The following is a description of a gene set: species: Homo sapiens Genes up-regulated in growing IMR90 cells (fibroblast) after knockdown of RB1 by RNAi. from publication Chicas A, Wang X, Zhang C, McCurrach M, Zhao Z, Mert O, Dickins RA, Narita M, Zhang M, Lowe SW (PMID 20385362) Human Gene Set: CHICAS_RB1_TARGETS_GROWING The RB protein family (RB, p107, and p130) has overlapping and compensatory functions in cell-cycle control. However, cancer-associated mutations are almost exclusively found in RB, implying that RB has a nonredundant role in tumor suppression. We demonstrate that RB preferentially associates with E2F target genes involved in DNA replication and is uniquely required to repress these genes during senescence but not other growth states. Consequently, RB loss leads to inappropriate DNA synthesis following a senescence trigger and, together with disruption of a p21-mediated cell-cycle checkpoint, enables extensive proliferation and rampant genomic instability. Our results identify a nonredundant RB effector function that may contribute to tumor suppression and reveal how loss of RB and p53 cooperate to bypass senescence., and this is the list of marker genes: TOX, AKR1C1, NMI, ADAMTS2, BAALC, NFYB, FAP (fibroblast activation protein alpha), CXCL12, DCN, ANPEP, MCM3, ANP32E, NUPR1, C1orf21 (chromosome 1 open reading frame 21), AXL, GPC6 (glypican 6), PPIG, GINS2, CNTN3, CCDC80, GASK1B, HMMR, MCM7, CENPH, PRICKLE1, CDCA8, CHAC2, PEAR1, CTDSPL2, CDCA7, HAS2, PCDH7, IMPA2, TBL1XR1, PCOLCE, TTK, LUM, CCNB2, DHCR24, CERS6, NAV2, ZFHX4-AS1, CORIN, PLPP3, HERC4, CCNE2, MEIS2, SMARCC1, LRRC15, PSG5, APOBEC3B, RFC4, RUNX1T1, SCARA3, KCNK2, IGFBP3, USP1, RBP1, CRYBG1, EXOSC8, TNFAIP8, UHRF1, TTC3 (NCBI Gene Id 7267), KCNN2, GINS1, KIF20A, RIF1, TMSB15A, SSRP1, CCBE1, NLRP1, TIFA, ELOVL2, JAM2, IFI16, GMPS, SLFN11, NASP, TIMELESS, SCD, CA12, ADGRG6, TOP2A, ADAMTS6, PCLAF, NUSAP1, CDC7, C2CD5, SHMT2, SLC1A4, OLFML3, CDC25B, RARRES1, LSM2, TMEM106C, CENPF, COL3A1, NR2F2, PHGDH, OXTR, ALDH1L2 (NCBI Gene Id 160428), GTSE1, HAUS1, DPF3, DPYSL3, PSAT1, BNC2, KIF4A, DNAJC9, ZNF22 (zinc finger protein 22), PRIM1, NCAPG2, CASP6, MSH2, SULF1, NRXN3, TPX2, PYGL, SLIT2, NEK2, SGO2, S1PR3, LMNA, MSH6, PTX3, MEST, SMC3, CAVIN1 (NCBI Gene Id 284119), CLDN11, KNL1, GAS2L3, MAGI2-AS3, STXBP6, B3GALT2, CBX5, MCM2, PRSS12, DEPDC1, ASNS, POLE2, ANKRD28, C1R, SMC4, KIF14, RPA3, MARCKS, CCNA2, IQGAP3, RGS4, ATRX, WASHC3, CDC20, EZH2, ANKRD13A, THSD4, KCNMA1, CENPA, FBXO11, ASPM, FABP5, SLC14A1, BUB1, LIN7A, CCNB1, PTN, DEK, JADE1, PGAP1, MGARP, FGF1, CDC42BPA, DDIT4, SUPT16H, FBLN1, PDGFD, UBR7, CDKN2A, MCM6, RAD51AP1, LXN, MATN2, TNFSF4 (TNF superfamily member 4), NRGN, SYNE3, RALGPS2, CDCA7L, EGR1, TSPAN5, LRRC17, FIGNL1, RBBP8, LTBP2, CAV1, ANXA3, MYLK, MCM4, NIBAN1, CACYBP, TICAM2, GPM6B, TRAM2, SMC2, POSTN, RBMS3, EZR, BUB1B, DOCK10, TMPO, BGN, NFXL1, PSIP1, EIF4EBP1, PCK2, FOXM1, LDB2, RNASEH2A, FAM72C, PSPH, TPR, SPIN4, CLU, GMNN, ITGB3BP, NSD2, VAT1L, C1QTNF2, CDH6, ARL4A, IDH2, CDKN3, HPRT1, SCUBE3, STMN3, CENPK, LSAMP, HELLS, NREP, CEP57, NRP1, RNF138 (NCBI Gene Id 51444), ANO1, TMEM97